Given this list of marker genes CTU2, URM1, CTU1, TRMU, MOCS3, here is a description of the gene set: The addition a sulfur atom to a nucleotide in a tRNA molecule. Human Gene Set: GOBP_TRNA_THIO_MODIFICATION species: Homo sapiens